Given this list of marker genes Ppp2r3d, Ppp3cb, Ctdnep1, Dusp10, Pten, Nceh1, Ppp1r12a, Ptpn5, Ppp6c, Dusp18, Ppm1g, Ptprh (NCBI Gene Id 545902), Phpt1, Ubash3b, Fam220a, Ppp1cb, Il3, Ptprc, Ppp4r3b, Ptpro, Dusp29, Ptprs, Ptpn2, Ptpn3, Ptprj, Epm2a, Ppp3r1, Dusp11, Ptprf, Ppm1m, Ptprb, Timm50, Ppp2r5a, Dusp5, Ppm1e, Ptprm, Ppm1j, Stk11, Dusp22, Ptpn6, Ptprz1, Dusp6, Ppm1d, Ptprk, Ppp1cc, Ppp4r3a, Dusp21, Ptpn11, Ctdsp2, Ppp2r1a, Sdhaf2, Bcl2, Tns2, Ppm1f (NCBI Gene Id 71214), Ptpn7, Ptpru, Ctdp1, Dusp26, Ptpn13, Ptprr, Ppm1a, Mtm1, Dusp19, Acp4, Dusp1, Ppp2r5d, Ptpn9 (protein tyrosine phosphatase, non-receptor type 9), Dusp3, Ptpn12, Pdxp, Eya3, Btrc, Fbxw11, Ptpn22 (NCBI Gene Id 19260), Ppm1b, Ppp2ca, Cttnbp2nl, Ptpn1, Pdp1 (pyruvate dehydrogenase phosphatase catalytic subunit 1), Ppp3ca, Cdc14b, Dusp2, Ppp1r15a, Ppp5c, Mtmr3, Ctdspl2, Pptc7, Ppp3cc, Ssh1, Ssh2, Eya2, Ptprt, Ppp1ca (NCBI Gene Id 19045), Ppp2r2a, Dusp7, Ctdsp1, Eya1, here is a description of the gene set: The process of removing one or more phosphoric residues from a protein. Mouse Gene Set: GOBP_PROTEIN_DEPHOSPHORYLATION species: Mus musculus